Given this list of marker genes ZFAND1, ECPAS, RAD23A, ADRM1, UBD, PSMG1 (NCBI Gene Id 8624), PSMF1, SACS, USP14, UBAC1, UCHL5, USP13, WFS1, BAG6, RAD23B, DNAJB2, PSMD14, PSME4, here is a description of the gene set: Human Gene Set: GOMF_PROTEASOME_BINDING studied in species Homo sapiens Binding to a proteasome, a large multisubunit protein complex that catalyzes protein degradation.